Given this list of marker genes ATP6V0E2, PYCARD, C1orf162, GPRIN3, C17orf100, NUDT16, CH25H, LST1, TSHZ3, F13A1, TUBA4A, PHF19, CALCOCO2, UBE2E2, XAF1, ADORA3, ABCG2, DNMT1, MLKL, ITPRIPL1, EGR2, MPP1, SETD7, TSPAN32, SP110, GNPDA1, SYNE3, CDK4, CD33, KATNB1, PLA2G15, HS2ST1, SNAI3, ARHGAP15, HK3, HYCC1, MBOAT1, PDZD11, NAGA, CBL, PARVG, SLC37A2, RRS1, PAPSS1, PTGS1, STAC, DIP2B, VWA8, IL17RA, TLR4, CCDC14, OAS2, CPPED1, CCDC86, ATP6V0A1, ST6GAL1 (NCBI Gene Id 6480), CYSLTR1, GINS3, ARMC10, EXOSC4, TMEM60, PLEKHF2, ZFP36L2, ARHGAP17, ADCK2, UBE2L6, LNPK, MAPRE2, ARHGAP18, DIAPH1, TK2, CCND3, HAVCR2, TRIP6, PNPO, HCFC2, LYL1, CST4, CLEC11A, CARD6, FEZ2, DUSP23, OSGEP, CMTM3 (CKLF like MARVEL transmembrane domain containing 3), EBPL, HIVEP3, PLOD3, ATP1A1, SMAD1, BCL6, GRAMD4, SLC19A1, IL27RA, FARSB, CASP8, ZNF202, ADCY7, TBC1D5, EMB, POLD1, PEMT, CMPK2, TNFAIP8L2, DENND4C, ING2, SPG21, CDCA7L, UCHL3, CCR5, MARCHF1, MACROH2A1, CHPT1, FERMT3, PRPF19, TEP1, BRPF1, JADE1 (NCBI Gene Id 79960), VAV1, C16orf54, PRMT5, NRGN, POGK, TAGAP, VPS45, ERCC1, TAPT1, FHL3, DIAPH2, VCL, ZNF558, SNU13, ARHGEF6, CAMK2D, DAP, CD81, CALR, CD99, TRIT1, MIF4GD, SLFN11, PAK1, RAB31, FLVCR2, SLC17A9, CD1C, DCUN1D4, UQCRC1, NAGK, SH3BGRL3, S100A4, OTULINL, LRRC8C, IFI44, MIOS, GNAI3, MTMR14, ARMCX5, EIF4EBP1, INPP5D, CXCR2, DMAC1, IRAG2, VASH1, NAT10, NCAPH, CD200R1, BIN2, PDXK, PRKACB, CCR1, TIFA, AHCY, LMO2, CARD9, KIAA0930, PA2G4, PLXDC2, CST3, DOCK5, POMGNT2, MILR1, CHEK2, CSTB, EVL, WDR26, SORD, SEPTIN9, RAC2, ARV1, RGS18, TBL1XR1, MGST2, MPPE1, DGLUCY, MRPL4 (mitochondrial ribosomal protein L4), CHD1L, GSPT2, ZNF641, here is a description of the gene set: species: Homo sapiens from publication Gu Z, Chhabra AY, Alard P, Warner DR, Kosiewicz MM (PMID 23643295) Genes up-regulated in macrophages: untreated versus TGFB2. Human Gene Set: GSE45382_UNTREATED_VS_TGFB_TREATED_MACROPHAGES_UP F4/80+ macrophages treated with TGFb2 are potently tolerogenic. Our understanding of the molecular mechanisms mediating the development of these tolerogenic properties is incomplete. We used microarray analysis to identify molecules that are involved in the tolerogenic mechanisms in murine TGFb-treated macrophages.